Given this list of marker genes CDK4 (cyclin dependent kinase 4), CDKN2A, CDK6, here is a description of the gene set: studied in species Homo sapiens The CDKN2A gene consists of four exons, exon 1beta, exon 1alpha, exon 2 and exon 3, going from the proximal to the distal gene end. There are two promoters in the CDKN2A gene locus. The promoter located between exons 1beta and 1alpha regulates transcription of the p16INK4A mRNA, which consists of exon 1alpha, exon 2 and exon 3 (only partially translated), and encodes a cyclin-dependent kinase inhibitor p16INK4A (also known as CDKN2A isoform 1, p16, INK4A, CDKN2A, CDK4I or MTS-1). The promoter located upstream of exon 1beta regulates transcription of the p14-ARF mRNA, which consists of exon 1beta, exon 2 (partially translated) and exon 3 (untranslated). The p14ARF mRNA is translated in a different reading frame from the p16INK4A mRNA and produces the tumor suppressor ARF (also known as p14ARF or CDKN2A isoform 4), an inhibitor of MDM2 E3 ubiquitin ligase-mediated degradation of TP53 (p53).<br>Wild type p16INK4A is able to form a complex with either CDK4 or CDK6 and prevent formation of catalytically active CDK complexes consisting of CDK4 or CDK6 and D-type cyclins (CCND). Thus, p16INK4A prevents hyperphosphorylation of RB-family proteins, required for initiation of DNA replication in RB1-competent cells. Expression of p16INK4A increases in response to strong oncogenic signaling, leading to accelerated cellular senescence (programmed cell cycle arrest). Expression of p16INK4A also increases after excessive proliferation, including that following oncogene activation by mutation in vivo. Loss-of-function of p16INK4A frequently occurs in cancer, usually through loss of p16INK4A protein expression due to promoter hypermethylation or CDKN2A gene deletion. Missense, nonsense and frameshift mutations in the CDKN2A locus can also impair p16INK4A function through expression of non-functional substitution mutants or truncated proteins. Germline intronic CDKN2A mutations that create aberrant splicing sites and result in expression of non-functional splicing variants of p16INK4A have been reported in familial melanoma. A CDKN2A gene mutation in the region encoding the 5'UTR of p16INK4A, reported in familial melanoma, creates a novel translation start codon and diminishes translation from the wild type start codon. However, mutations in the non-coding regions of the CDKN2A gene are rare.<br>Based on cell culture studies, p16INK4A defects enable precancerous and cancerous cells to delay or evade senescence under oncogenic signaling stress. Establishment of an in vivo role of oncogene induced senescence, and thus an in vivo role of p16INK4A in this context, have been difficult owing to lack of specific biomarkers and interconnectedness of various senescence triggers.<br>Genomic deletions in the CDKN2A locus affect p14ARF, unless they are limited to exon 1alpha. The p14ARF promoter can also be hypermethylated in cancer, leading to loss of p14ARF expression. Some missense mutations occurring in exon 2 of the CDKN2A gene affect the p14ARF protein sequence. However, p14ARF mutants usually appear to be less functionally compromised than their p16INK4A counterparts. Most functional tests on p14ARF mutants examine the effect of mutations on MDM2 binding and TP53-mediated transcription of CDKN1A (p21), as well as sub-nuclear localization of p14ARF. Still, there are poorly explored functions of p14ARF that may be significantly affected in mutant p14ARF proteins detected in cancer. Reactome Pathway: Evasion of Oncogene Induced Senescence Due to p16INK4A Defects part of: Diseases of Cellular Senescence